The following is a description of a gene set: Human Gene Set: GSE17721_CTRL_VS_POLYIC_8H_BMDC_UP mouse primary BMDCs were stimulated with tlr ligands and gene expression changes were profiled on Affymetrix arrays Genes up-regulated in comparison of control dendritic cells (DC) at 8 h versus those stimulated with poly(I:C) (TLR3 agonist) at 8 h. from publication Amit I, Garber M, Chevrier N, Leite AP, Donner Y, Eisenhaure T, Guttman M, Grenier JK, Li W, Zuk O, Schubert LA, Birditt B, Shay T, Goren A, Zhang X, Smith Z, Deering R, McDonald RC, Cabili M, Bernstein BE, Rinn JL, Meissner A, Root DE, Hacohen N, Regev A (PMID 19729616) studied in species Homo sapiens, and this is the list of marker genes: EIF3F, OAZ2, MKNK2 (MAPK interacting serine/threonine kinase 2), TECR, LTBP3, SNX15, NEDD8 (NEDD8 ubiquitin like modifier), CENPB, MGAT2, TRMT1, YWHAH, TAX1BP3, ACADVL, AKAP8, IL6R, RETREG2, NABP2, RAD17, QRSL1, COA6, TRIM39, MAP4K4, DNAJC9, BATF, MMP12, OPN3, MBP, ATP5IF1, CERS5, TUBB2B, PWP2, TNRC6B, RPL30, METTL18, ZFAND2A, GADD45GIP1, GDE1, TESK2, LIMK1, ATP5F1A, NCBP1, WDR45 (NCBI Gene Id 11152), CLEC6A, SSR4, ICE2, PTDSS2, NME3, RAMP1, TTI1, PTH1R, BHLHE22, LSM4, ANKRD54, SAE1, HNRNPL, PDE1C, DHX15, SESN1, MDH1, CDK5, SPTLC1, RGS19, SCD, BCAP29, GAS2, DMAC1, RTCB, SYPL1, SFXN3, CLIC1, PIP4K2A, UBXN1, SCEL, PUM3, CXCR4, GLMP, SDHAF2, RGL2, NOLC1, TARDBP, PEPD, NLK, POLR1E, DDX41, DIDO1, NFIL3, SELENOP, NUCB1, CLNS1A, NDUFAB1, VDAC1, SMIM14, CTSA, RASSF2, ASGR2 (asialoglycoprotein receptor 2), MRPL3, IFI30, ACAT1, VCP, TMEM208, POFUT2, CCDC167, REXO2 (NCBI Gene Id 51640), PAG1, ATP2A1, NDUFA13, NDUFA11, MED22, TIMM8A, ARHGDIB, BCAM, PDXK (NCBI Gene Id 8566), TMEM216, APIP (NCBI Gene Id 51074), ACKR1, S100A1, RNF5, RPLP1, ACRBP, RPL12, OSBPL2, TIA1, TRIM59, CYP4F3, CETN2, XBP1, PGD, CCT8, C1QC, ADAM15, NCAPH, PCNX3, CDKAL1, HAUS4, FUOM, SEC16A, ZNF287, ORMDL2, CUEDC2, MYL6, CERS2, CUTA, GTF3C2, BCAP31, DHX16, STK16, PRKAG1, NCOR2, RNASE4, CCR2, SELENON, ADRB2, TF, NSMF, GCLM, HLA-DMA, UFSP2 (NCBI Gene Id 55325), PNO1, MRAS, MRPS2, C1QBP, RARS2, ZFAND1, RPS15A, FAU, NUFIP1 (nuclear FMR1 interacting protein 1), ACTR1B, LDLR, STMP1, MTTP, GNPNAT1, FTSJ1, RNF7, SASH3, CD81, HOXA1, IPO4, ARPC1A, SLF2, TCN2, PRPS2, FAM162A, ODC1, CCNA2, RERE, XPOT, NHP2, ANLN, LEPROT, TMEM101, ASF1B, MPHOSPH9, KCNK13, TMUB2, LSM3, ACTR6, RXRB (retinoid X receptor beta), CROT, ATP5MC3